Given this list of marker genes POU4F2, NTRK2, EPHA7, KIT, ROR1, EPHB6, MPZL1, NTRK1, BDKRB2, INSR, ERBB2, FLT1, RAPGEF1, EPHA4, EPHA2, EPHB3, EPHB2, CD7, TEK, NRTN, PAX6, DDR2, MUSK, CD4, CYP1B1, CD8B, KDR, EPHB4, DOK1, EPHB1, CD8A, LCP2, PTPRG, PDGFRA (NCBI Gene Id 5156), EDN2 (endothelin 2), PDGFRB, here is a description of the gene set: Genes in the cancer module 51. Human Gene Set: MODULE_51 species: Homo sapiens